The following is a description of a gene set: Genes up-regulated in serrated vs conventional colorectal carcinoma (CRC) samples. Serrated colorectal carcinomas (CRCs) are morphologically different from conventional CRCs and have been proposed to follow a distinct pathway of CRC formation. Despite studies of single molecular events in this tumor type, the diagnosis of serrated CRC relies on morphology and the putative unique biological character of these tumors has not been established. Here we show that the gene expression profiling of 37 CRCs separated serrated and conventional CRCs into two distinct branches in unsupervised hierarchical clustering (P-value 7.8 x 10(-7)), and revealed 201 differentially expressed genes representing potential biomarkers for serrated CRC. Immunohistochemistry was utilized to verify the key findings in the 37 CRCs examined by expression profiling, and a separate validation set of 37 serrated and 86 conventional CRCs was examined to evaluate the candidate biomarkers in an extended sample material. Ephrin receptor B2, hypoxia-inducible factor 1-alpha and patched appeared as proteins important for genesis of serrated CRC. This study establishes serrated CRCs as a biologically distinct subclass of CRC and represents a step forward in the molecular classification of these cancers. The study also provides a platform to understand the molecular basis of serrated CRC and in long term may contribute to the development of specific treatment options for this tumor type. species: Homo sapiens from publication Laiho P, Kokko A, Vanharanta S, Salovaara R, Sammalkorpi H, Järvinen H, Mecklin JP, Karttunen TJ, Tuppurainen K, Davalos V, Schwartz S Jr, Arango D, Mäkinen MJ, Aaltonen LA (PMID 16819509) Human Gene Set: LAIHO_COLORECTAL_CANCER_SERRATED_UP, and this is the list of marker genes: ATP6V0E1, CAPZA1, CTSB, NOP10, PLEKHB2, DPYSL2, HNRNPC, RO60, TCF4, CNIH4, PLS1, NCOA4, MBD4, MACF1, DAD1, PDGFC, SERF2, CAV1, PMP22, HLA-DRB1, ELK3, RPL36AL, ARPP19, CSNK1A1, IFI27, ATP1B1, IL6ST, SPARC, IGHG1, GDI2, HIF1A, IGKC, NPTN, OPTN, ADAM10, SVIL, PRKAR1A, PALLD, RASSF2, AP2M1, ATP2B1, SRP14, SEC62, TOMM7, ANXA5, CSRP2, TM4SF1, CCN2, SDCBP, IGLC2, SGCB (sarcoglycan beta), EMP3, EMC7, LAMB1, PELI1, ANP32E, SPG21, CHMP2B, NXN, RBX1, ARPC2, PDLIM5, SELENOT, PDIA6, PPIC, MORF4L2, NEDD8, DPYD, EMP1, ATP5F1C, PLA2G4A, MYL12B (myosin light chain 12B), B2M, MYL6, SNRK, ORMDL2, C5orf15, GBP1, CLINT1, BNIP3L, SC5D, RIN2, LGALS1, NDUFV2, SEC24A, HSPA8, YME1L1, C1S, TAGLN2, PXDN (peroxidasin), LSM3, PAM, GCNT3, LAMC1, CEACAM6, IQGAP1, SNRPE, SUMO2, RBM34, VDAC3, DDX60, ANXA2 (annexin A2), MRPS14, MFAP1, VAPA, PRNP, EPRS1, ARL8B, EMC3, LCP2, COMMD3, MON2, PSMD4, BCAP29, POSTN